The following is a description of a gene set: Genes negatively differentially expressed in cell type: CD8+ T cell upon treatment with cytokine: IL-4 in mouse lymph nodes in vivo. Cytokines mediate cell-cell communication in the immune system and represent important therapeutic targets. A myriad of studies have highlighted their central role in immune function, yet we lack a global view of the cellular responses of each immune cell type to each cytokine. To address this gap, the authors created the Immune Dictionary, a compendium of single-cell transcriptomic profiles of more than 17 immune cell types in response to each of 86 cytokines (>1,400 cytokine-cell type combinations) in mouse lymph nodes in vivo. A cytokine-centric view of the dictionary revealed that most cytokines induce highly cell-type-specific responses. For example, the inflammatory cytokine interleukin-1β induces distinct gene programmes in almost every cell type. A cell-type-centric view of the dictionary identified more than 66 cytokine-driven cellular polarization states across immune cell types, including previously uncharacterized states such as an interleukin-18-induced polyfunctional natural killer cell state. species: Mus musculus Mouse Gene Set: CUI_T_CELL_CD8_IL4_RESPONSE_DN from publication Cui A, Huang T, Li S, Ma A, Pérez JL, Sander C, Keskin DB, Wu CJ, Fraenkel E, Hacohen N (PMID 38057668), and this is the list of marker genes: Atp11b, Myl6, Tuba1a, Arrb2, Neat1, Sh2d1a, Ltb, Tdrp, Limd2, Macf1, Slamf6, Txk, Cd2, Actn1, Jakmip1, Arl5c, Foxo1, Utrn, Tent5a, Cxcr4, Anxa6 (annexin A6), Klf6, Sp100, Cd7, Btg1, Btg2, Hspa1b, Tcf7, Zbtb20, S1pr1, Emb, Rsrp1, Nkg7, Txnip, Fos, Gmfg, Madd, Ctla2a, Ccl5, S100a11, S100a10, Traf1, Atp1b3, Kif21b, Stk38, Il2rg, Pou2f2, Smc4, Gpsm3 (G-protein signalling modulator 3 (AGS3-like, C. elegans)), 9930111J21Rik2, Slc12a7, Cd27, H2az2, Gramd1a, Zfp36l1, Gm2a, Ctsd, Stim1, Rgs2 (regulator of G-protein signaling 2), Tagln2, Il7r, Ahnak, Sh3kbp1, Acp5 (NCBI Gene Id 11433), Arhgef18, Npc2, Rasgrp2, Igkc (immunoglobulin kappa constant), Jun, Cd47, Tmem71, Frmd8, Ostf1, Wnk1, Sptbn1, Shisa5, Dgka, Dapl1, Creb1, Crip1, Tspo, Esyt2, Adgre5, Malt1, Uqcrh, Gimap6, Srpk2, Vim, Lsp1, S100a6, Lck, Hspa1a, Celf2, Cd3d, Il18r1, Map4k4, Gnai2, Msn, Itgb7, Bin1, Tsc22d3 (NCBI Gene Id 14605), Gimap3, Ypel3, Ikzf2, Emp3, Ipcef1, Samhd1, Jak1, Kcnn4, Cd52, Ssh2, Klrd1, Il6ra, Zfp36l2, Clic1, Cox7a2l, Cd37, Sell, Selenop, Arl6ip1, Lgals1, Akap13, Ldlrap1, Pde7a, Cd3e, Zyx, Fxyd5, Arhgef1, Adcy7, Ehd3, Neurl3, Laptm5, Arhgap45, Rgs10, Tecpr1, Mxd4, Xcl1, Cdkn2d, Chd3, Stk4, Pik3ip1, Smpdl3a, Cmah, Stk17b, Ifngr1, Cdk2ap2, Spn, Saraf, Myh9, Cnn2, Pnrc1, Prkd2, Ankrd44, Klf2, Cd3g, Flna, Plec, Dnajc15, Gpx4, Kmt2e